Given this list of marker genes Fabp4, Cdkn1b, Id2, Pparg, Fas, Impa2, Atp1a3, Gsk3a, Grin2a, Lig4, Slc13a5, Gria1, Nfatc4, Nfatc3, Shh, Myog, Cebpa, Adcy7, Slc13a2, Calr, Cdh1, here is a description of the gene set: Mouse Gene Set: GOBP_RESPONSE_TO_LITHIUM_ION Any process that results in a change in state or activity of a cell or an organism (in terms of movement, secretion, enzyme production, gene expression, etc.) as a result of a lithium (Li+) ion stimulus. studied in species Mus musculus